The following is a description of a gene set: Human Gene Set: GOBP_REGULATION_OF_MESENCHYMAL_CELL_PROLIFERATION Any process that modulates the frequency, rate or extent of mesenchymal cell proliferation. A mesenchymal cell is a cell that normally gives rise to other cells that are organized as three-dimensional masses, rather than sheets. studied in species Homo sapiens, and this is the list of marker genes: NFIB, BMP4, MYCN, IRS2, BMPR1A, PDGFA, FOXF1, ZEB1, LRP5, FOXP2, FGFR2, WNT5A, PRRX1, TGFBR2, LMNA, PHF14, STAT1, KDR, SOX9, SMO (NCBI Gene Id 6608), SHOX2, MYC, IHH, WNT11, WNT2, CTNNB1, FGF9, SHH, ARHGAP5, TBX1, ISL1, SIX1, CTNNBIP1, FGFR1, CHRD